Given this list of marker genes UBE2N, RNF20, RNF40, UBE2A, STUB1, UBE2V1, UBE2U, UBE2V2, UBE2B, here is a description of the gene set: Any complex that possesses ubiquitin conjugating enzyme activity. species: Homo sapiens Human Gene Set: GOCC_UBIQUITIN_CONJUGATING_ENZYME_COMPLEX